Given this list of marker genes CMTM7, CCDC34, LIPE, BAX, ZNF254, PTEN, PPIF, GOLGA3, ENSA, LDHC, RFTN1, ZNF266, CENPC, RDH16, GALK2, MARCHF1 (NCBI Gene Id 55016), EBNA1BP2, ALG13, SAA1, HDAC7, SMTN, KMO, SLITRK5, ZMYND15, ARF1, PIN1P1, SARS2, SNAP25, PPP2R5A, CTNNA1, SAMD10, TSPAN2, G6PD, ARGLU1, LY6G5C, SENP2, AOC3, CST3, ACOT1, PDCD5, HAPLN1, NMU, KRT35, CNBD2, RBFOX2 (RNA binding fox-1 homolog 2), KPNA1, XPA, MAGEC1, ATP10A, AQP2, RBM3, BPI, MUC20, TRIM7, PPM1D, KLK8, GBE1, ATP11A, CIRBP, PRKAG2, UQCRC1, USP25, SPI1, CDKL2, SNX8, PTGR1, RUBCN, FPGS, BAHCC1, MADCAM1, COPS2, ENTPD2, PGGT1B, WDR83OS, SPATA9, MRPS34 (mitochondrial ribosomal protein S34), CDKN2B, RAD23A, DLGAP5, THAP12, SPATC1L, PRSS3, ASB6, TESC, CHCHD6, LAMC1, B4GALT4, COL2A1, GPAM, C19orf47, NPTX2, SIMC1, IMMP2L, CLPS, CADM3, DDX5, INPP5D, TNFSF8, CAND1, ACP6, CTH, GDF15, TESK1, KRT6A, CEP97, AAR2, PRPF6, SLIT3, IL18R1, PTPRB, TLR10, ATP2C1, CXCL6, TRPC5, IMMT, INSL6, TRIOBP, PLBD1, AIM2, RBBP8, JAM3, STXBP5-AS1, NDFIP1, SV2B, SLC10A1, ITPRID2, DNAL4, GOLM1, FAU, OTOF, HK2, LRATD1, ST3GAL1, TAF4, CAPZB, KPNA2 (karyopherin subunit alpha 2), MND1, SLC35F6, RAB3GAP2, LEMD3, KPNB1, PNO1, KCNJ15, LITAF, ARFGAP1, SLC25A51P1, PFN2, CCDC85B, ZWINT, MARK3, CXCL1, HES2, CUL4B, B3GAT1, SLC4A10, DMRT1, BBS4 (NCBI Gene Id 585), PQBP1, SMPD3, THRB, TRMU, UBE2G2, BORCS6, COMMD10, DAAM1, YIPF1, CXCL16, OTUB1, SORL1, HIF1AN, PTGER2, ALDH1B1, SSX1, GEMIN8, H2BC5, NPFF, EXOSC7, FOXA2, PAPPA, DSC2, SP110, ACTA2, ECSIT, HDAC10, E2F5, ABL1, CYP4F8, P3H4, SERPINH1, ITGB7, SETDB1, RANBP17, JAGN1, MS4A6A, PTP4A1 (protein tyrosine phosphatase 4A1), ACLY, PAH, SOX4, RNF4, LTBP4, RANBP3, KHK, GDE1, MBOAT7, AOPEP, TTK, PARL, TAF7, ZNF135, MARK4, CCL16, INSR, MEPCE, PPP6R1, ZNF77, CYP51A1, IER3, TRMT6, TRIM47, SLC25A47, SYT17, DCBLD2, PLEKHA2, BCL6, PPFIA4, CAMK1, RBM14, SPAG16, ATP12A, LTK, SNAPC4, AKAP3, ABCA1, RNF114, COX7A1, GPNMB, SUCLG1, DUT, NMI, PTRH2, OAZ1, TNK2, TRIM66, CAMP, MAP3K7CL, LAMC3 (laminin subunit gamma 3), JPH2, NRSN1, ARFRP1, PIK3C3, KLRC2, ZNF160, MAN2C1, CD84, POLR2J3, SRSF2 (NCBI Gene Id 6427), FAIM, ACD, PRPH2, SLC35E1, NTS, INSL4, H2BC1, TMEM242, TP53BP2, OGFOD1P1, SFTPA1, CFH, NOX4, PFN1, HSPB8, TCEA1, GDF3, PURA, MMP9, H1-9P, TUG1, STAT2, RBM26, IREB2, GPR107, HEXIM1, ARF6, GFI1, BIN1, POU3F4, ADD1, SFRP2, LGALS14, PORCN, EVC2, PLK1, LMCD1, CENATAC, WFDC1, PAQR6, here is a description of the gene set: Special AT-rich binding protein 1 (SATB1) acts as a global regulator of gene expression by recruiting various corepressor or coactivator complexes, thereby establishing a unique chromatin structure at its genomic targets in a context-dependent manner. Although SATB1 acts predominantly as a repressor via recruitment of histone deacetylase 1 (HDAC1) complexes, the precise mechanism of global repression is not clear. Here we report that SATB1 and C-terminal binding protein 1 (CtBP1) form a repressor complex in vivo. The interaction occurs via the CtBP1 interaction consensus motif PVPLS within the PDZ-like domain of SATB1. The acetylation of SATB1 upon LiCl and ionomycin treatments disrupts its association with CtBP1, resulting in enhanced target gene expression. Chromatin immunoprecipitation analysis indicated that the occupancy of CtBP1 and HDAC1 is gradually decreased and the occupancy of PCAF is elevated at the SATB1 binding sites within the human interleukin-2 and mouse c-Myc promoters. Moreover, gene expression profiling studies using cells in which expression of SATB1 and CtBP1 was silenced indicated commonly targeted genes that may be coordinately repressed by the SATB1-CtBP1 complex. Collectively, these results provide a mechanistic insight into the role of SATB1-CtBP1 interaction in the repression and derepression of SATB1 target genes during Wnt signaling in T cells. Human Gene Set: PURBEY_TARGETS_OF_CTBP1_NOT_SATB1_UP from publication Purbey PK, Singh S, Notani D, Kumar PP, Limaye AS, Galande S (PMID 19103759) studied in species Homo sapiens Genes up-regulated in HEK-293 cells (fibroblast) upon knockdown of CTBP1 but not of SATB1 by RNAi.